The following is a description of a gene set: Activation of NIMA Kinases NEK9, NEK6, NEK7 species: Mus musculus Mouse Gene Set: REACTOME_ACTIVATION_OF_NIMA_KINASES_NEK9_NEK6_NEK7, and this is the list of marker genes: Nek9, Ccnb1, Cdk1, Ccnb2, Plk1